The following is a description of a gene set: Human Gene Set: GSE40274_FOXP3_VS_FOXP3_AND_IRF4_TRANSDUCED_ACTIVATED_CD4_TCELL_DN species: Homo sapiens Genes down-regulated in CD4 T conv over-expressing: FOXP3 versus IRF4 and FOXP3. The transcription factor FoxP3 partakes dominantly in the specification and function of FoxP3+ CD4+ T regulatory cells (Tregs), but is neither strictly necessary nor sufficient to determine the characteristic Treg transcriptional signature. Computational network inference and experimental testing assessed the contribution of several other transcription factors (TFs). Enforced expression of Helios or Xbp1 elicited specific signatures, but Eos, Irf4, Satb1, Lef1 and Gata1 elicited exactly the same outcome, synergizing with FoxP3 to activate most of the Treg signature, including key TFs, and enhancing FoxP3 occupancy at its genomic targets. Conversely, the Treg signature was robust to inactivation of any single cofactor. A redundant genetic switch thus locks-in the Treg phenotype, a model which accounts for several aspects of Treg physiology, differentiation and stability. from publication Fu W, Ergun A, Lu T, Hill JA, Haxhinasto S, Fassett MS, Gazit R, Adoro S, Glimcher L, Chan S, Kastner P, Rossi D, Collins JJ, Mathis D, Benoist C (PMID 22961053), and this is the list of marker genes: TAF5L, HSPB1, STX12, KLHL6, USP28, ARSB, ITGA4, SPRTN, CDCP1, FAM89A, CCR4, TMEM154, PMM1, CST7, TRAF5, ANKH, PRDM1, OXSM, RBPMS2, RNF43, SHOX2, LYPLA2, ZNF229, P2RX7 (purinergic receptor P2X 7), SLC25A33, GLIPR1, GMFG, ZNF764, HUS1 (NCBI Gene Id 3364), LCP1, VTI1B, CYBB, CDC25B, RPS6KA3, IKZF3, AMPD3, IGHM, RNASE4, TRPM6, MTHFD1L, RIPK4, GRHL1, TRAF3IP2, FITM2, SOAT2, PTPRE, FUT11, SERINC3, CR2, MAF, SNW1, AVEN, FASLG, PTPN13, DIPK2A, ARMC7, ZNF493, ITGAV, SMAD3, CNN2, PPM1J, CSTF2, PPP2R5A, NXPE4, DENND2B, TMEM126A, CASS4, GPR155, QRSL1, SLC46A3, VAMP5, CERS4, GPR15, SLC25A20, RFLNB, RAPGEF5, CEMIP2, SLC22A5, CCR2, CPT1A, FZD5, SERPINB1, AP3M2, LCA5, S100A11, POLR3D, ANGPTL2, TBC1D14, FBXL14, IL18, EMC2, UAP1L1, GPLD1, IPCEF1, POU2AF1, CDKN2C, WEE1, GLB1, SLAMF6, PDE2A, COBLL1, CC2D2A, LNX2, BSN, SMCO4, LIG4, ZDHHC2, CCDC127, CSRP2, PLCL1, PDE4DIP, HEXA, TOR4A, NLN, DAPP1, ARRDC4, SNX8, RTL3, IL10RA, TMED5, SORBS1, S1PR4, FBXO41 (NCBI Gene Id 150727), MANSC1, JADE1, EVI2B, BTBD6, TAFA3, TAF9B, CYTH4, CLIP1, GJB2, C5orf24, AREL1, MOSMO, TEC, THTPA (thiamine triphosphatase), RNF128, TKTL1, ANKRD6, GALM, MAN2A1, PTPRJ, IL10, MATK, SHROOM2, PXYLP1, ENPP1, SLC35C2, HLA-DRB1, SLBP, FPGT, H1-0, ECI1, PGAP6, SQOR, CCR10, DIPK1A, ARRB1, DHRS7, BTLA, TMEM51, PLEK, SEC11C, LGALSL, NHSL2, FAM210A, CPM, BTBD19, MMD, SRPK3, SDCBP2, SMPDL3A (NCBI Gene Id 10924), IL10RB, ATP10D, PABPC1L, GCNT1, CD22, GLRX, PHACTR2, IQGAP2, CDIPT, PARP16, TMEM209, SNAI2, C15orf39, TSR1, DENND4C, RDM1, HSD11B1, CCDC126, S100A6, IDE, KLRG1, CRIP1, TBX21, LCLAT1 (lysocardiolipin acyltransferase 1), SHE, SLC8B1